Given this list of marker genes PAMR1, SLX4, GPR183, COQ6, HEXIM1, SETD1A, MYO5B, APLNR, PHRF1, SUSD6, SLC13A2, ADGRE5, SMARCD2, INO80D, DDHD1, TERB2, ACYP1, STT3B, ORC5, GPS2, CDH7, ZFP82, KLHL41, OAS1, TMEM87A, SLC24A4, EIF2B4, PDE6D, IRF7 (interferon regulatory factor 7), SRCAP, TNFAIP6, TES, SMCO4, ZNF841, METTL2B, ZMIZ2, NCOA3, ZNF444, APPBP2, FYB1, BRD9, IAPP, ZMYM4 (NCBI Gene Id 9202), KCND2, CFP, ACRBP, ELMOD2, TAF4B, MAP3K1, CMYA5, SATB1 (NCBI Gene Id 6304), MFAP1, TM4SF20, MAP3K14, IREB2, TRAF3IP1, RAMP1, PITHD1, SFSWAP, AXIN1, EMC1, RGP1, CERT1, SMTNL1, TET2, NDUFAF4, SNRNP200, MRPL38, LDHD, ASXL3, NCOA1, VPS26A, NGDN, LTO1, CHORDC1, LSM14B, GDF5, PLEKHB1, CCDC54, RRAD (RRAD, Ras related glycolysis inhibitor and calcium channel regulator), DLG3 (discs large MAGUK scaffold protein 3), SHMT1, KIF3C, BANK1, OXT, HNRNPC, ENTPD6, SNN, RPL10, CD86, HAO2, B4GALT1, ADIPOR2, CYP3A7, TIMM10, TUBGCP4 (tubulin gamma complex component 4), TMC4, FAM86B2, RRP9, GLYCTK, OSBPL11, ART5, SIT1, DGKE, RBM14, ATF6B, RTEL1 (regulator of telomere elongation helicase 1), LRP6, CCND2, RGL2, RAP2B, SLC39A7, CNOT2, RARG, TFAP2C, ZMYM3, CPLANE1, MARF1, FAM149B1, C2, PCGF6, CALHM6, PAF1, CCL28, ASB6, MED13L, THRAP3, CTCF, RNF19A, RRM2B, BBS2, SPACA4, MORC2, TLR7, PCYT2, HEPACAM2, DCAF1 (NCBI Gene Id 9730), APOBEC2, GIMAP6, BARX1, DHRS4, TUT4, ZNF157, AKAP9, BTC, CDK11B, NAA60, AREL1, CRHR1, HOOK1, KIAA1217, DDX5 (NCBI Gene Id 1655), PHTF2, SARAF, ANGPTL6, RELN, PRMT9, GUCD1, CNEP1R1, SIRT7, SFXN2, CAVIN4 (NCBI Gene Id 347273), TRIM15, STX6, TMEM86B, HS3ST4, AQR, ENTPD5, RREB1, PRSS44P, STK40 (NCBI Gene Id 83931, serine/threonine kinase 40), STIM2, XCL1, GPATCH4 (NCBI Gene Id 54865), METTL3, CCM2, GGA2, SLC36A1, RPS3, CRK, MTARC2, PIGX, RTN4R, ANGPTL1, RCCD1, UBE3B, PPP4R3B, NELFA, SHLD1, SUCO, TNS3, ANO1, DAG1, GANAB, KRTAP4-12, PPM1K, FAM163B, ESCO1, PHF6, SMYD1, here is a description of the gene set: Human Gene Set: GSE14308_TH1_VS_NAIVE_CD4_TCELL_DN species: Homo sapiens Genes down-regulated in comparison of Th1 cells versus naive CD4 T cells. Multipotential naïve CD4+ T cells differentiate into distinct lineages including T helper 1 (Th1), Th2, Th17, and inducible T regulatory (iTreg) cells. The remarkable diversity of CD4+ T cells begs the question whether the observed changes reflect terminal differentiation with heritable epigenetic modifications or plasticity in T cell responses. We generated genome-wide histone H3 lysine 4 (H3K4) and lysine 27 (H3K27) trimethylation maps in naïve, Th1, Th2, Th17, iTreg, and natural (n)Treg cells. We found that although modifications of signature cytokine genes (Ifng, Il4, and Il17) partially conform to the expectation of lineage commitment, critical transcription factors such as Tbx21 exhibit a broad spectrum of epigenetic states, consistent with our demonstration of T-bet and IFN-gamma induction in nTreg cells. Our data suggest an epigenetic mechanism underlying the specificity and plasticity of effector and regulatory T cells and also provide a framework for understanding complexity of CD4+ T helper cell differentiation. from publication Wei G, Wei L, Zhu J, Zang C, Hu-Li J, Yao Z, Cui K, Kanno Y, Roh TY, Watford WT, Schones DE, Peng W, Sun HW, Paul WE, O'Shea JJ, Zhao K (PMID 19144320)